The following is a description of a gene set: Occipital encephalocele A type of encephalocele (that is, a a protrusion of part of the cranial contents including brain tissue through a congenital opening in the cranium, typically covered with skin or mucous membrane) in the occipital region of the skull. Occipital encephalocele presents as a midline swelling over the occipital bone. It is usually covered with normal full-thickness scalp. species: Homo sapiens Human Gene Set: HP_OCCIPITAL_ENCEPHALOCELE, and this is the list of marker genes: TXNDC15, CEP290, B4GAT1, TCTN3 (tectonic family member 3), C2CD3, INPP5E, POMK, MSX2, RPGRIP1L, LARGE1, POMGNT1, TMEM231, COL18A1, HOXD13, TCTN2, SMO, CYP26B1, ARL13B, MKS1, FKTN, TMTC3, CC2D2A, TMEM67, SF3B2, PAK2, LAMB1, FKRP, ALX4, POMT1, TMEM107, B9D2, HSPG2, B9D1, GMPPB, POMT2, TMEM218, CSPP1 (centrosome and spindle pole associated protein 1), KIAA0586